The following is a description of a gene set: studied in species Homo sapiens Human Gene Set: GOCC_INNER_KINETOCHORE The region of a kinetochore closest to centromeric DNA which contains many CENP proteins organized in various subcomplexes including CENP-C, CENP-LN, CENP-HIKM, CENP-OPQUR and CENP-TWSX, but excluding the CENP-A containing heterochromatin., and this is the list of marker genes: CENPU, H3-3B, CENPW, CENPS, ORC2, H3-3A, CENPT, CENPQ, CENPM, CENPO, CENPN, CENPL, CENPI, CENPX, CENPP, CENPC (centromere protein C), ITGB3BP, CENPK, CENPH